Given this list of marker genes TPSG1, DUSP1, APBB2, MSI2, TENM3, TRPC5, SOCS7, DCAF16, TPR, RGS7BP, MRFAP1, SPTSSB, ABHD17B, ANO4, WARS2, BLTP3A, SEPTIN11, XDH, MADCAM1, PSME4, RLIM, TTLL7, MCF2L, PTPN2, MCEE, GUCY1A2 (NCBI Gene Id 2977), AR, THAP2, ITGA9, NCKAP1, CDKN1A, ATMIN, POLR1B, TESK2, PGBD2, PCLO, GPR174, ZNF407, SLC35E1, RPTN, TIAM1, PPM1A (NCBI Gene Id 5494), IRF2BPL (NCBI Gene Id 64207), HOXC6, GK2, IL12B, TRAPPC11, DNAAF9, NLRP2B, PTPRB, ITPRID2, USP28, DGKG, VPS50, HTR1D, SPATA19, MAGOH, ADGRV1, AFF3, RNF169, WDFY3, RHOBTB3, RHEB, CYBRD1, YWHAB, NR3C2, SLC35F3, COL2A1, TMEM217, IL1RAP, ZBTB26, ARHGEF2, LIN54, METTL4, CES4A (carboxylesterase 4A), FKBP3, MPC2, ATP8B4 (NCBI Gene Id 79895), here is a description of the gene set: Human Gene Set: MIR11399 species: Homo sapiens Genes predicted to be targets of miRBase v22 microRNA hsa-miR-11399 in miRDB v6.0 with MirTarget v4 prediction scores > 80 (high confidence targets). from publication Chen Y, Wang X (PMID 31504780)